The following is a description of a gene set: Abnormal optic chiasm morphology studied in species Homo sapiens A structural abnormality of the optic chiasm.The optic chiasm, located below the hypothalamus, is a partial crossing of the optic nerves. Human Gene Set: HP_ABNORMAL_OPTIC_CHIASM_MORPHOLOGY, and this is the list of marker genes: UCHL1, DYRK1A, ALDH1A3, OPA1, DIAPH1, TRAPPC12, LETM1